The following is a description of a gene set: Reactome Pathway: BH3-only proteins associate with and inactivate anti-apoptotic BCL-2 members Bcl-2 interacts with tBid, BIM, PUMA, NOXA, BAD, BMF, resulting in inactivation of BCL2. Binding of BCL2 to tBID inhibits BID-induced cytochrome C release and apoptosis. BH3 only proteins associate with and inactivate anti-apoptotic BCL-XL. part of: Intrinsic Pathway for Apoptosis studied in species Homo sapiens, and this is the list of marker genes: BAD, BBC3, BID, STAT3, PMAIP1 (phorbol-12-myristate-13-acetate-induced protein 1), BCL2, BMF, BCL2L11, BCL2L1